Given this list of marker genes Hint2, Park7, Sirt3, Hdac2, Sirt1, Klf15, Gsk3b, here is a description of the gene set: species: Mus musculus Mouse Gene Set: GOBP_NEGATIVE_REGULATION_OF_PROTEIN_ACETYLATION Any process that stops, prevents or reduces the frequency, rate or extent of protein acetylation.